Given this list of marker genes SLC6A3, ITGA2, AP4E1, WDR45B, CYB5A, WDR81, BCL11B, AP4M1, GP1BA, COLGALT1, IDUA, CA8, RAD51, IREB2, PROC, RNASEH2C, GP1BB, TUBG1, MCCC2, DNASE1L3, APC2, CACNA1E, GNB1 (NCBI Gene Id 87729), CTNNA2, ANKLE2, CNP, NALCN, DPH5, MOCS1, TMX2, PSMC1, OSTM1, CACNA1D, AUH, TUBB2B, TANGO2, CNPY3, SLCO2A1, DEGS1, SOX10, SCN2A, ITGA2B, PPFIBP1, KIF2A, KIF5C, HPGD, RAB18, PNP, YIF1B, SLC16A2, SLC1A4, SMARCB1, SEPSECS, SIX6, DCX (NCBI Gene Id 1641), AHDC1, SLC5A6, LSM11, WARS2, ELOVL4, CNTNAP2, VPS53, CHD8, FBXW11, ASNS, RNASEH2B, ATP13A2, DENND5A, SPR, STXBP1, PDHX, GLYCTK, AUTS2, H4C5, ADGRG1, CDC40, FILIP1, RNU7-1, MTFMT, RNF125, WDR73, PCDH12, VLDLR, SHQ1, IDH2, MRPS22, DYNC1H1, NDUFAF4, GABRA2, ITPR1, NAXD, PRDM13, SEC31A, SAMHD1, ATP5F1A, SLITRK2, MED23 (NCBI Gene Id 9439), GRIN1, CPLX1, RBM10, SDHAF1, NFU1, RNASEH2A, OTUD6B, IBA57, TUBB3, MECP2, MCOLN1, DCC, KANK1, SYT1, IDH1, SRPX2, IFIH1, SPTAN1, ADD3, SYNJ1, PCBD1, HMGCL, RNU4-2, COL4A2, TBCE, CLN8, CAMK2B, CLIC2, PPIL1, SPTBN1, SCN4A, GOT2, HSD17B10, CYB5R3, CD109, ALS2, GSX2, KARS1, ARX, GLB1, SCN3A, ADAR, DTYMK, PIGA, ATP8A2, COASY, PRDM8, SLC32A1, PET100, TREX1, TUBA1A, AP4S1, NSRP1, PLA2G6, MOCS2, CPSF3, CIC, UNC80, SOX2, COG2, ATP6V0A1, RANBP2, PHGDH, NTN1, SLC19A3, NDE1, TBC1D20, AFG2B, EXOC2, FUCA1, GRIA4, NRCAM, DNAL4, KCNC2, CSF1R, MINPP1, PI4KA, NDUFAF5, ARSA, ITGB3, PRNP, LIAS, SHMT2, here is a description of the gene set: studied in species Homo sapiens Cerebral palsy Human Gene Set: HP_CEREBRAL_PALSY Cerebral palsy describes a group of permanent disorders of the development of movement and posture, causing activity limitation, that are attributed to nonprogressive disturbances that occurred in the developing fetal or infant brain. The motor disorders of cerebral palsy are often accompanied by disturbances of sensation, perception, cognition, communication, and behavior, by epilepsy, and by secondary musculoskeletal problems.